Given this list of marker genes SUMO1, HDAC4, POM121, NDC1, CBX5, SUZ12, NUP188, SATB1, NUP35, CBX8, NUP133, SUMO2, AAAS, SATB2, SEH1L, NUP58, NUP160, NUP155, NUP214, RNF2, H4C1, CBX4, UBE2I, NUP205, NUP42, L3MBTL2, NUP107, NUP85, PHC3, HDAC2, POM121C, NUP210, BMI1, RAE1, PIAS1, NUP93, HDAC1, SUMO3, NUP43, NUP153, NUP88, NUP54, NUP98, PIAS2, RING1, PHC1 (polyhomeotic homolog 1), SCMH1, NUP50, TPR, PHC2, SEC13, NUP37, NUP62, RANBP2, CHD3, ZBED1, PCGF2, CBX2, here is a description of the gene set: part of: SUMO E3 ligases SUMOylate target proteins species: Homo sapiens SUMOylation of proteins involved in chromatin organization regulates gene expression in several ways: direct influence on catalytic activity of enzymes that modify chromatin, recruitment of proteins that form repressive (e.g. PRC1) or activating complexes on chromatin, recruitment of proteins to larger bodies (e.g PML bodies) in the nucleus. Reactome Pathway: SUMOylation of chromatin organization proteins